Given this list of marker genes Col5a3, Col6a6, Col7a1, Col2a1, P3h2, Plod3, Col1a2, Col6a5, Col15a1, Col6a1, Tll2, Col18a1, Col9a1, Col11a2, Col25a1, P3h3, Col13a1, Col12a1, Col20a1, Col19a1, P4hb, Pcolce2, Col24a1, Col17a1, Plod2, Col8a2, Col10a1, Bmp1, Col8a1, Col4a2, Ppib, Pcolce, Col4a5, Col4a6, here is a description of the gene set: electronically inferred by orthology from the curated human pathway species: Mus musculus This event has been computationally inferred from an event that has been demonstrated in another species.<p>The inference is based on the homology mapping from PANTHER. Briefly, reactions for which all involved PhysicalEntities (in input, output and catalyst) have a mapped orthologue/paralogue (for complexes at least 75% of components must have a mapping) are inferred to the other species. Reactome Pathway: Collagen biosynthesis and modifying enzymes part of: Collagen formation